Given this list of marker genes Akr7a5, Ephx2, Alox15, Tmem86b, Lta4h, Ephx1, Dhcr7, Ephx3, Alox12, Ephx4, Ebp, Tmem86a, here is a description of the gene set: Catalysis of the hydrolysis of any ether or thioether bond, -O- or -S- respectively. studied in species Mus musculus Mouse Gene Set: GOMF_HYDROLASE_ACTIVITY_ACTING_ON_ETHER_BONDS